Given this list of marker genes SRGAP1, MYT1L, ENC1, GRIA2, MTURN, CHL1, SCD5 (stearoyl-CoA desaturase 5), DPP6, ADRA2A, MAP6, SLA, DOCK4, C8orf34, FGF9, DNAL4, LRRC8B, GAREM1, SH3PXD2A, LHFPL4, DLG2, LNX1, DYNC1I1, SEMA3C, KRT31, ADGRG6, NDRG1, CACNG8, EPHB1, PTPRD, TTC14, MAPT, CPTP, CRYM, MIR124-1HG, RUNX1T1, LEMD2, SNAP91, SORL1, SATB2, ESYT2, GLRA2, NIN, MNT, TMEM132B, AFDN-DT, ARPP21, MEF2C, RBFOX1, TNIK, HSPA12A, NEUROD2, ATAD2B, ACYP2, GUSBP11, MEGF8, ABHD6, RNF213, MLLT3, AGPAT3, SERP2, NTM, IQGAP2, SHC2, LONRF2, EPHA3, CEP126, MIAT, here is a description of the gene set: Human Gene Set: ZHONG_PFC_C7_ORG_UNDERGOING_NEURONAL_DIFFERENTIATION from publication Zhong S, Zhang S, Fan X, Wu Q, Yan L, Dong J, Zhang H, Li L, Sun L, Pan N, Xu X, Tang F, Zhang J, Qiao J, Wang X (PMID 29539641) studied in species Homo sapiens